The following is a description of a gene set: species: Homo sapiens Human Gene Set: GOMF_PROTEIN_KINASE_ACTIVITY Catalysis of the phosphorylation of an amino acid residue in a protein, usually according to the reaction: a protein + ATP = a phosphoprotein + ADP., and this is the list of marker genes: PRP4K, CCL5, GPRC5A, VRK2, CCNF, CDKL1, SRMS, SPRY2, TGFB1, CDK18, MADD, AJUBA, TTN, BMP2K, RPS6KA3, VRK3, MAST3, PRKACB, SRPK2, CDK4, CDKN2D, PRKAG1, NRG3, MAPK8IP1, NEK5, AATK, MAP3K12, CCNT2, PAK3, CLK1, PPM1D, VEGFA, ANKRD42, EFEMP1, KIT, RSKR, INSR, TNK1, CALM3, TXK, CCL2, CDK17, ROR1, EFNA3, BRD4, NME2, GDF10, DMPK, ERBB2, PRKACG, NCK1, PNCK, STK38, GRK3, FLT3, PKM, PRKCI, CCNE1, HIPK3, RPS6KB1, RPS6KA5, BLK, MMD, CCNJ, GCN1, ULK1, CCNA1, NUAK2, CDK5R1, MAP3K8, APC, SMCR8, STK33, CDK20, STK36, PIM3, DUSP22, GRK5, SOCS3, LYN, PAK1IP1, IL6ST, STK25, ABL1, ADCK5, ATP23, BRSK1, ULK4 (NCBI Gene Id 92216), JAK1, ATG13 (NCBI Gene Id 9776), ALK, ADCK2, MAPK7, LTF, CSNK2B, PAK2 (NCBI Gene Id 9106), EPHA8, MKNK1, CSNK1G2, AKT2, AREG, CIB1, ACVR1C, MAP3K4, SLK, MAP3K7, SRPK1, STK24, IRGM, CCNY, TTBK2, CAMK4, CAB39, MT3, WEE1, CCNO, RPLP1 (ribosomal protein lateral stalk subunit P1), CCL8, MAP3K21, EPHA6, MAPK3, ALKAL1, PHKG2, STK17B, CCNL1, CDK14, PIK3R4, CSNK2A1, RPS6KA2 (NCBI Gene Id 6196), LRRK2, CDK8, DBF4B, PIK3CG, CCND1, MLKL, TAOK1, CCNA2, NPR2, MAP4K5, PIK3CA, MAP2K1, INKA1, FGFR3, CAB39L, STK4, CCNB1, CDK16, CDKN2A, CCNK, SOCS1, PKMYT1, PRKAR2A, CLK4, MAP3K19, AKT3, PRKCB, MUSK, YES1, ACSL1, CIITA (NCBI Gene Id 4261), MELK, BCKDK, PAN3, TAOK2, LILRB4, RASSF2, PRKCA, MOS, NEK6, EFNB3, TOM1L1, GSK3A, MNAT1, KAT2B, EPGN, MAPK4, PIM1, CHP1, STRADA, FAM20A, CDK1, SAV1, BRD3, JAK2, CDKL3, CAMK2D, TOPBP1, CXCL10, TRIO, PRKCE, DDR1, PARP8, RAC2, MAP3K14, IGF1, SGK1, CCND3, CAV1, TWF1, STK16, STK11 (NCBI Gene Id 6794), TAOK3, ALPK1 (alpha kinase 1), GUCY2C, BMPR2, STK35, PXK, MYLK2, PDK2, CDK7, SPEG, ACVR2A, IRAK4, HASPIN, EPHA4, CDK5R2, HTRA2, PDGFRA (NCBI Gene Id 5156), TCL1A, CASK, RPS6KL1, BCR (BCR activator of RhoGEF and GTPase), ATAD3A, MAP4K4, MERTK, PTK2, PAK6, KSR1, RAF1, TGFBR3, LIMK1, MAP2K6, NTRK1, NRP2, CSNK1G3, AVP, CAMKV, CDC7, TP53RK, POMK, TRIB3, MAP3K5, CLK2, PRKCG, ALPK3, IGF2, PRKRIP1, STK39, EIF2AK4, MAP3K20 (NCBI Gene Id 51784), CHEK2, TESK1, SCYL1, SMO, MAP3K6, ANKK1, SGK3, PSKH1, AMHR2, PPP1R9B, MLST8, PDE8A, RIOK2, HBEGF, PSKH2, STK3, HSPB8, EIF2AK3, TSSK2, PIKFYVE, TBK1, NEK4 (NCBI Gene Id 8380), MKNK2, DUS2, MAPK15, EFNA5, EIF2AK2, CKS1B, MAP3K13, PDIK1L, ERBB4, PRKAB2, EPHA3, GPRC5B, FER, MARK4, GRK6, CSNK1A1L, MAP2K5, RACK1, RICTOR, GPRC5D, MARK2, CDKN2B, CAMK2B, ALS2 (alsin Rho guanine nucleotide exchange factor ALS2), LMTK3, EPHA2, PRKG1, FGFRL1, AURKA, SIK2, BRSK2, BRDT (bromodomain testis associated), MOB3A, CHKA, YWHAB, ACVR1B, TIE1, PLK2, CHEK1, HUNK, SRC, PDK1, STK26, STK19, RPS6KA1, PRKAG3, STK17A (NCBI Gene Id 9263), STK32B (serine/threonine kinase 32B), CCNB3, MAPK12, ACVRL1, PKN2, EPHB4, STYK1, SPRED1, TCL1B, CSNK2A3, IGF2R, FAF1, CCNC (NCBI Gene Id 892), CILK1, MATK, LTBP4, DAZAP2, ARAF, ACVR2B, CCNI2, MAPK10, CDC37, MAP2K3, MAPK11, AAK1 (NCBI Gene Id 652453), MARK1, ERBB3, CAD, HIPK1, ANKLE2, PLK5, LIMK2, TNK2, CDKL5, NEK7, RIPK3, MAP2K2, NRBP1, MET, CCL3, CDKN1A, ABL2, EPHA1, MST1R, CAMK1G, GMFG, FLT1, MAPK9, TPX2, CAMKK2, TESK2, NUAK1, BUB1, GRK1, CCNI, SPEGNB, TRIM28, SPRY4, TLK1, EREG, CAMK1, DYRK1A, QARS1, BTC, AKT1S1, CDK11A, EPHA5, ROR2, PYDC1, IRAK3, PRKD1, TSSK6, GSKIP, DYRK4, TTBK1, HMGB1, EPHB1, CDK6, TGFA, CHUK, ATM, STK31, CKS2, GSK3B, FLT4, TRIB1, PDGFRB, OXSR1, DAPK3, PRKCZ, HTR2A, BUB1B, ELP4, TEK, LATS1, STK10, BRD2, INCA1, RYK, MAP3K1, BMPR1B, MINK1, PIK3CB, NEK11, WNK4, SCYL2, CDKN1B, NCKAP1L, PRKAA1, EIF2AK1, HJV, BMPR1A, DDR2, CIT, FGFR2, ELP3, CSK, ZAP70, INKA2, CDKN1C, CSNK2A2 (casein kinase 2 alpha 2), EPHA7, CSF1R, ERN2, ACVR1, RPS6KC1, STKLD1, GMFB, TEX14, TTK, PKIB, CEP43, NRK, EEF2K, PRKY, MAK, ALKAL2, ILK, HSPB1, LTBP1, RHEB, DDX3X, PKN1, NPR1, FGFR4 (NCBI Gene Id 2264), AKT1, MAP3K10, SIK1, PHKA1, MYLK, BMP7, MAP4K3, HCK, WNT11, STK32A, RPS6KA6, MOK, CDK12, CSNK1G1, COQ8B, MARK3, TSSK1B, MAP4K2, TOP1, MASTL (NCBI Gene Id 84930), CNPPD1, PARVA, NME7, CRIM1, CAMK2N2, MAPK8, CDC42BPG, CCNG2, MBIP, DCLK3, KSR2, PRKCD, MAST2, EGF, PLK3, GRK4, RIOK1, NBN, NEK1, PEAK1, PKDCC, HIPK2, TAB1, PRKDC, SYK (NCBI Gene Id 6850), DGKQ, AURKB, TRIB2, RIPK4, SMG1, MAP3K11, AFAP1L2, MAPK1, TBCK, PLK4, ANGPT4, GRK7, MOB1A, LMTK2, RIPK2, TYK2, CDKL4, CCDC88A, RET, OBSCN, MYLK3, GUCY2F, NEK3, FERMT2, DCLK1, NEK10, CAMK2G, CDK19, CASP3, ADIPOQ, SGK2, MTOR, ROS1, MAPKAPK2, PAK5, FES, GUCY2D, FAM20C, RIPK1, NGF, JAK3, PTK7, IRAK1, IBTK (inhibitor of Bruton tyrosine kinase), EPO, BMP2, AXIN1 (axin 1), NEK2, GHRL, MAPKAPK5, PRKAR2B, MAPK13, NIM1K, TAF1L, HTATIP2, PINK1, AGAP2, HSP90AB1 (NCBI Gene Id 3326), SRPK3, ATR, ADCK1, CPNE3, CCNL2, CDK5, DNAJC3, PDK4, SH3BP5, PRKD2, CDK2, PIM2, TRIM24 (NCBI Gene Id 8805), DSTYK, TSSK3, TGFBR1, UHMK1, IQGAP1, RNASEL, CSNK1E, PRKACA, TSSK4, HYAL2, PREX2, HEXIM1, CDC42BPA, MTCP1, SNRK, MAP3K2, RPS6KA4, BMP4, PARP16, PREX1, DCLK2, MYO3B, LRRK1, NLK, PRKX, NEK9, EGFR, PARP6, PTK2B, CDK9, CDK10, PKIA, PKIG, AXL, CDK15, MOB2, MAP3K15, TLK2 (tousled like kinase 2), GRK2, MAST4, FYN, IRAK2, BAZ1B, MMD2, PRKCH, PGK1, MAP2K7, STRADB, MACROH2A1, GSTP1, C8orf44-SGK3, NTRK3, PRKAR1A, PRKAG2, PPP5C, PEAK3, KIDINS220, PPEF2, RAD50, SLC27A1, CALM2, PASK, RPS6KB2, SBK3, SAMD15, CCNJL, HIPK4, KALRN, GRM5, DAPK1, IKBKB, GPRC5C, TEC, NRG1, ULK2, KDR, EFNA4, GREM1, ITK, CAMKK1, MAPK14, PRAG1, ABI1, DYRK3, HSPA5, DAB2IP, FRK, LATS2 (NCBI Gene Id 95108), PTK6, DAPK2, PHKG1, DUSP19, SPRED2, PRKD3, CCNP, MAPK6, PRKCQ, ERN1, CCNQ, DYRK1B, AURKC, TGFBR2, IGF1R, CDKL2, ITPRIP, ANKRD54, DCAF1, SNCA, MOB1B (MOB kinase activator 1B), EPHB6, MYLK4, PRKAA2, WEE2, NRP1, SBK2, MAP4K1, CALM1, NEK8, TNIK, ERCC6, DELE1, CCNH, BMX, STK38L, ALPK2, CAMK1D, WNK1, NPM1, MAPRE3, PRKAR1B, DAXX, LTK, TRPM7, PBK, TYRO3, CDK13, HEXIM2, PCK1, FGFR1, SPDYA, SH3BP5L, CAMK2N1, MAP3K9, CDKN2C, DUSP3, CCNB2, ULK3, PRKG2, PDGFRL, INSRR, EPHA10, CAMK2A (calcium/calmodulin dependent protein kinase II alpha), CCNE2, PDK3, PHKA2, DBF4, MAP3K3, SFN, LCK, ITPKA, SIK3, PRKRA, STAP1, GHR, LRP6, TNNI3K, ETAA1, PKN3, TRPM6, ROCK1, CCNT1, EPHB2, GDF2, WNK2, DYRK2, CDK11B, CD24, MSTN, PLK1, WNK3 (NCBI Gene Id 65267), CLK3, MOB3C, CDK3, MOB3B, SOSTDC1, CD40LG, STK32C, RGCC, RPTOR, CCND2 (cyclin D2), GAK, EPHB3, TGFBR3L, MAPKAPK3, PAK4, DEPTOR, NRBP2, MAPK8IP2, FASTK, SBK1, CCNG1, MAST1, PTPRC, TAF1, NTRK2, BRAF, PAK1, CDC42BPB, PIK3C3, CSNK1A1, YWHAG, ROCK2, FGR, BTK, PPP1R1B, MYO3A, CSNK1D, VRK1, STK40, PDPK1, COQ8A, MAP2K4 (mitogen-activated protein kinase kinase 4), IKBKE, TNKS1BP1, TESC, RIOK3